The following is a description of a gene set: species: Mus musculus Mouse Gene Set: GOBP_NEGATIVE_REGULATION_OF_HYDROLASE_ACTIVITY Any process that stops or reduces the rate of hydrolase activity, the catalysis of the hydrolysis of various bonds., and this is the list of marker genes: Arl2, Serpinb9d, Csta2, Gapdh-ps15, Mkks, Tmed2, Usp17le, Apoa1, Tmem132c, Serpinb6e (NCBI Gene Id 435350), Spink1, Gapdhrt2, Slc27a4 (solute carrier family 27 (fatty acid transporter), member 4), Angptl4, Rgs2 (NCBI Gene Id 19735), Lrrk2, Bin1, Serpina5, Reck, Gmip, Spry2, Serpinb1a (NCBI Gene Id 66222), Tmem225, Spink5, Serpinb6d, Hpn, Stfa3 (stefin A3), Apcs, Serpinb8, Serpinb9f, Crb2, Sh3bp4, Tmed10, Serpinb13, Serpinb6a, Gapdh, Gpsm1, Serpinb9b, Cstdc3, Ubxn1, Stfa2l1, Arfgef1, Serpinb9g, Serpinb9h, Hras, Vtn, Atp5if1, Lepr, Rap1gds1, Ptx3, Spink2, Cst7, Stfa2, Rdx, Plin5, Amot, Ecm1, Serpinb9e, Angptl3, Park7, Cstdc5, Cstb, Bag4, Spock3, Serpinb6c, Cstdc4, Plxnb3, Gapdhrt, Rcc2, Spock1, Serpinb1c, Dab2ip, Serpine2, Eppin, Csta1, Rrp1b, Cstdc6, Tnf, Bbs4, Serpine1, Fetub, Tmbim6, Terf1, Stfa1, Lrch1, Grn, Sort1, Chp1, Angptl8, Apoc3, Apoa2, Csta3, Spink6, Cst3, Uri1, Ttc8, Wnk1 (NCBI Gene Id 406236), Timp3, Nos3, Dffa, Serpinb1b (NCBI Gene Id 76168), Camk2a, Pla2r1, Serpinb6b, Timp2, Epm2a, Terf2, Spry1, Cast, Apoc1, Gzma, Timp1, Nos1, Serpinb9, Neil1, Wfdc6a, Akt1, Serpinb9c